Given this list of marker genes LYN, LIMD1, SHROOM1, DLG4, FRS2, MYO1E, CYTH3, TMEM47, PARK7, FRMD5, CYTH1, TBCD, EFNB2, CDH22, MPP7 (MAGUK p55 scaffold protein 7), CTNNA3, CDH4, RND1, JCAD, PKP1, CDH26, CAMSAP3, WTIP, CTNND1, EZR, TMOD3, FAT2, ANXA1, TJP2, SORBS1, BMPR2, ZYX, EHD4, ANXA2, FLOT1, AJAP1, DLG1, NECTIN4, PPP1CA, SMAD7, NOTCH1, JUP, CDH7, RDX (radixin), CCDC85B, AJUBA, SNAP23, ADAM15, AJM1, ARVCF, CDH6, CDH10, EFNA5, PKP2, TLN1, DAG1, SYNM, DSP, EPHA4, WNK3, CDH11, ADD1, CDH1, FRMD4B, CYTH2, CTNNA1, PRICKLE4, ESAM, CRB1, VEGFA, NDRG1, TRPV4, CTNNB1, CDH9, CDH2, CDH13, NECTIN2, LLGL2, SHROOM2, DLL1, CTNND2, FER, ADAM10, FLOT2, PLEKHA7, DSC2, FRMD4A, TSPAN33, CCDC85C, NEXN, CCDC85A, LIN7C, CDH5, CDH15, VCL (NCBI Gene Id 7414), KRT18, LDB3, XIRP1, PALS1, NPHP1, ACTB, PDLIM3, BAIAP2, TRIM29 (NCBI Gene Id 23650), CDH17, NECTIN1, MPP3, PDLIM1, MICALL1, PVR, JAG1, CDH19, MSN, KIFC3, AHI1, POF1B, CDH8, EIF4G2, ABI2, ALOX15B, PARD3, PAK4, CEACAM1, CNN3 (NCBI Gene Id 1266), PGM5, STXBP6, DLG2 (NCBI Gene Id 283225), FERMT2, CDH24, PACSIN2, SHROOM4, VEZT, TJP1, EPB41L5, LLGL1, SCRIB, CDHR3 (cadherin related family member 3), PDZD11, MYH9, CDC42EP1, PTPRM, DLG3, DLG5, RAB10, HMCN1, SPTBN4 (spectrin beta, non-erythrocytic 4), CTNNA2, TNKS1BP1, CDH18, PKP4, KLHL24, NECTIN3, NIBAN2, LIN7B, CDH20, LRRC7, PDLIM5, PARD3B, CDC42EP4, SSX2IP, CDH12, PKP3, PDLIM2, LAMA3, CD99L2, TMEM204 (NCBI Gene Id 79652), CDCA3, SHROOM3, CXADR, DDX6, LIN7A, PLPP3 (NCBI Gene Id 8613), PDLIM7, SDCBP, AFDN, NF2, ARHGAP24, MAGI1, APC, FMN1, BAIAP2L1, PIP5K1C, SH3BP1, TNK2, MPP4, PTPRK, S100A11, PDLIM4 (PDZ and LIM domain 4), CDH3, IGSF21, PPP1R9B, here is a description of the gene set: A cell-cell junction composed of the epithelial cadherin-catenin complex. The epithelial cadherins, or E-cadherins, of each interacting cell extend through the plasma membrane into the extracellular space and bind to each other. The E-cadherins bind to catenins on the cytoplasmic side of the membrane, where the E-cadherin-catenin complex binds to cytoskeletal components and regulatory and signaling molecules. studied in species Homo sapiens Human Gene Set: GOCC_ADHERENS_JUNCTION